The following is a description of a gene set: Mouse Gene Set: GOBP_POSITIVE_REGULATION_OF_MACROPHAGE_DERIVED_FOAM_CELL_DIFFERENTIATION species: Mus musculus Any process that increases the rate, frequency or extent of macrophage derived foam cell differentiation. Macrophage derived foam cell differentiation is the process in which a macrophage acquires the specialized features of a foam cell. A foam cell is a type of cell containing lipids in small vacuoles and typically seen in atherosclerotic lesions, as well as other conditions., and this is the list of marker genes: Pla2g5 (NCBI Gene Id 18784), Cd36, Tnf, Nfkb1, Alox8, Il1b, Prkch, Csf2, Lpl, Agtr1a, Agt, Il18, Csf1, Pla2g3, Mapk9, Apob (apolipoprotein B), Msr1, Agtr1b